Given this list of marker genes RRP12, AGPAT2, SLC11A1, RGS1, RERGL, RGS14, THOC1, KRT23, CISD1, RAB33A, CPLANE2, EIF3J (eukaryotic translation initiation factor 3 subunit J), MVK, BFAR, ASAH1, GFOD3P, KLK6, SNRNP25, SIRPA, SBNO1, CSF3R, TTPAL, TRIM13, HUNK, RBBP8, DACH1, WDTC1, CBX2, LIPA, PLA2G5, CLEC4E, EXT2, TBX6, LIMK2, B4GALT5, GLUL, DOCK4, PCTP, MFSD5, MARCHF3, SLC5A7, NUDCD3, FCGR1A, COL11A1, GALNT3, CD80, SSX7, FAM13B, ARHGEF40 (NCBI Gene Id 55701, Rho guanine nucleotide exchange factor 40), USP11, URB2, RABGGTB, EIF4EBP1, VASP, NEU3, PHACTR1, PLPP3, TEX13A, FLAD1 (NCBI Gene Id 80308), S100A8, CD1E, LGALS4, ARC, LYPLA2P1, LRRC8E, FAM184A, P4HA2, PSD4, TMEM8B, PRRG1, INPP5B, MPO (NCBI Gene Id 4353), NTAN1, ILKAP, HYMAI, ADCYAP1, DCLRE1C, HTR2A, PLCH2, GCNT1, CCNT2 (cyclin T2), ATF1, ALCAM (NCBI Gene Id 214), CCN3, BTNL3, STXBP2, LRRFIP1, CACNA1F, UGT8, GAA, OGDH, CDH15, TCF25, LGR4 (leucine rich repeat containing G protein-coupled receptor 4), ACP3, ELOA2, TFEB, ZNF141, GPN3, BAMBI, TRIB1, ROM1, CAVIN3, ASH1L (NCBI Gene Id 55870), SPRY4, BCL3, JAG1, FNDC3B, ZNF587 (zinc finger protein 587), ACOT8, ITIH4, MBP, TNFRSF10C, CYBB, TYROBP, PLEKHJ1, KCTD5, LST1, CSGALNACT2, SORD, CELF1, STUM, CAMK2B, FGFR1, ANKRD36B, CDC37, PLEKHG6, PLA2G2F, CNNM1, S100A9, RANBP2, TMEM156, GFOD1, DCAF15, MYO1C, LILRA6, CYBA, CDH20, C1orf159, FRAT1, MYO5A, MGLL, THBS4, GALC (galactosylceramidase), SH2B1, KIR2DL1, PER2, CTSS, CTNNAL1, BCAS4, NUP133, GMIP, P2RY13, QPRT, NR1H2 (NCBI Gene Id 7376), TIPARP, ZNF721, CCDC9, DDX31, EVI2A (ecotropic viral integration site 2A), ZNF75D, PFN2, RRP7A, SSPN, PI4K2A, KL, SULT1E1, JOSD1, FAM131A, ANKRD46, FMR1 (fragile X messenger ribonucleoprotein 1), SYTL2, FOXRED2, SNN, CASQ1, PLXNC1, MLF1 (NCBI Gene Id 4291), PPP1CB, CPA4 (NCBI Gene Id 51200), TXNRD1, HMX1, BCKDHA, UBXN6, TUB, SYNE1, ATP10B, CADPS, MCF2L, EFNB2, PHACTR4, GABRP, GPR27, ZNF14, ZFPM2, SLC7A11, EML3, here is a description of the gene set: Human Gene Set: GSE3982_EOSINOPHIL_VS_BASOPHIL_UP Genes up-regulated in comparison of eosinophils versus basophils. In the present study we used Affymetrix oligonucleotide microarrays to produce gene transcription profiles for the major leukocyte types in humans. This comprehensive dataset enabled us to not only establish which genes were expressed in each leukocyte type, but also which genes were expressed in each subset after activation. The used of a comprehensive dataset of gene profiles from all the major human leukocyte subsets enabled a novel and powerful means for identification of genes associated with single leukocyte subsets, or different immune paradigms. species: Homo sapiens from publication Jeffrey KL, Brummer T, Rolph MS, Liu SM, Callejas NA, Grumont RJ, Gillieron C, Mackay F, Grey S, Camps M, Rommel C, Gerondakis SD, Mackay CR (PMID 16474395)